Given this list of marker genes RRAS2, CAV1, PLEKHG5, DEPDC1B, DSP, ALDH3A2, RBMX, ANKRD26, STMN2, MUC13, PIK3R1, STIP1, FAM135A, PTPN13, GRB7, PIK3R2, ARHGAP35, DST, FAM83B, DLG5, RND1, TMEM59, EPHA2, FRS3, FLOT2, CPD, PLXNA1, KIDINS220, EPSTI1, WDR6, UBXN11, CCDC88A, FRS2, TFRC, RASAL2, LEMD3 (NCBI Gene Id 23592), TXNL1, VANGL1, ARHGAP5, KIF14 (NCBI Gene Id 9928), VANGL2, PKP4, here is a description of the gene set: Human Gene Set: REACTOME_RND1_GTPASE_CYCLE RND1 GTPase cycle studied in species Homo sapiens